Given this list of marker genes Grin2d, Ptprf, Lrrtm2, Shank3, Ppfia2, Flot1, Lrrc4b (leucine rich repeat containing 4B), Ptprs, Grin2c, Lrfn1, Homer1, Lrfn4, Slitrk6, Grin2b, Slitrk3, Slitrk2, Lrrtm3, Ppfibp1, Ppfibp2, Grin2a, Sh3glb2, Slitrk1, Dlg3, Epb41l1, Lrfn2, Lrrtm4, Dlgap2, Dlg4, Ppfia3, Homer3, Grin1, Nlgn2, Lrrtm1, Slitrk5, Rtn3, Nlgn3, Slitrk4, Il1rapl2, Flot2, Lrfn3, here is a description of the gene set: electronically inferred by orthology from the curated human pathway studied in species Mus musculus Reactome Pathway: Protein-protein interactions at synapses This event has been computationally inferred from an event that has been demonstrated in another species.<p>The inference is based on the homology mapping from PANTHER. Briefly, reactions for which all involved PhysicalEntities (in input, output and catalyst) have a mapped orthologue/paralogue (for complexes at least 75% of components must have a mapping) are inferred to the other species. part of: Neuronal System